The following is a description of a gene set: Human Gene Set: FIRESTEIN_CTNNB1_PATHWAY from publication Firestein R, Bass AJ, Kim SY, Dunn IF, Silver SJ, Guney I, Freed E, Ligon AH, Vena N, Ogino S, Chheda MG, Tamayo P, Finn S, Shrestha Y, Boehm JS, Jain S, Bojarski E, Mermel C, Barretina J, Chan JA, Baselga J, Tabernero J, Root DE, Fuchs CS, Loda M, Shivdasani RA, Meyerson M, Hahn WC (PMID 18794900) Aberrant activation of the canonical WNT/beta-catenin pathway occurs in almost all colorectal cancers and contributes to their growth, invasion and survival. Although dysregulated beta-catenin activity drives colon tumorigenesis, further genetic perturbations are required to elaborate full malignant transformation. To identify genes that both modulate beta-catenin activity and are essential for colon cancer cell proliferation, we conducted two loss-of-function screens in human colon cancer cells and compared genes identified in these screens with an analysis of copy number alterations in colon cancer specimens. One of these genes, CDK8, which encodes a member of the mediator complex, is located at 13q12.13, a region of recurrent copy number gain in a substantial fraction of colon cancers. Here we show that the suppression of CDK8 expression inhibits proliferation in colon cancer cells characterized by high levels of CDK8 and beta-catenin hyperactivity. CDK8 kinase activity was necessary for beta-catenin-driven transformation and for expression of several beta-catenin transcriptional targets. Together these observations suggest that therapeutic interventions targeting CDK8 may confer a clinical benefit in beta-catenin-driven malignancies. species: Homo sapiens Genes required for CTNNB1 activity in DLD-1 cell (colon cancer with APC deletions), based on shRNA screen., and this is the list of marker genes: EPHA2, STK25, FER, ULK1, LATS1, CSNK1E, SRPK3, PLK4, LTK, DKC1, PLK1 (polo like kinase 1), GABRA3, KSR2, CAMKK2, FOXO4, SLK, MAP2K1 (mitogen-activated protein kinase kinase 1, NCBI Gene Id 5604), MAP3K14, PKN1, PDK3, CHEK2, DGKH, TAOK1, NRAS, DCLK2 (NCBI Gene Id 166614), PTK2B, CSNK1G3, CDK8, DAPK2, MAP3K20, RPS6KA1, SYT11